The following is a description of a gene set: Any process that modulates the rate, frequency or extent of membrane depolarization during an action potential. Membrane depolarization is the process in which membrane potential changes in the depolarizing direction from the resting potential. studied in species Homo sapiens Human Gene Set: GOBP_REGULATION_OF_MEMBRANE_DEPOLARIZATION_DURING_ACTION_POTENTIAL, and this is the list of marker genes: GJA5, CLCN2, SLMAP, PTPN3, RANGRF, MIR208A, CAV3, ANK3